Given this list of marker genes ACTN2, FHL1, NHERF1, LRRC38, SMDT1, LRRC52, ABCC9, LRRC26, PRKACA, ANK2, AKAP9, LRRC55, ANK3, RANGRF, AKT1, here is a description of the gene set: Human Gene Set: GOMF_CHANNEL_ACTIVATOR_ACTIVITY Direct interaction with a channel (binding or modification), resulting in its opening. A channel catalyzes energy-independent facilitated diffusion, mediated by passage of a solute through a transmembrane aqueous pore or channel. species: Homo sapiens